Given this list of marker genes Gigyf1, Tlcd4, Qki, Snx27 (NCBI Gene Id 97912), Ifrd1, Ulk2, Zfp607b, Tcf12, Map7d1, C3ar1, Cnr1, Arhgef18, Fbxl2, Marchf6, Exoc5, Atp6v1a, Osbpl8, Sacm1l, B230219D22Rik, Tmem221, Ikzf5 (IKAROS family zinc finger 5), Ntng1, Akap6, Msantd4, Clasp2, Vcan, Zfp644, Mapk1, Pdxp, Prtg, Il2, Nfasc, Nrp1, Pcdh9, Tfap2c, Ywhag, Hcn1, Fam91a1, Cpeb3, Aldh1a1, Mysm1, Bcap29, Spry4, Pdcd10, Abhd18, Adgrb3, Cdc14a, H2az1, Ranbp6, Slain2, Fnip2, Slc6a9, Ero1a, Jazf1, Septin11, Cep15, Rnf145, Tnrc6b, Qser1, Ccdc80, Pym1, Pakap, Astn1, Pdgfra, Zdhhc3, Myrip, Lysmd3, Apbb2, Dcun1d3, Tmem135, Dmwd, B4gat1, Hs2st1, Itpripl2, Reck (NCBI Gene Id 53614), Lmbrd1, Gria4, Zfp597, Kmt2a, Sipa1l2, Dusp3, Ppfia1, Prkce, Ct55, Chic1, Dstyk, Tada1, Arpc5, Hic2 (hypermethylated in cancer 2), Plcxd2, Stxbp5, Rnft1, Arfgef3, Tgfbr1, Tmem237, Urgcp, Ints8, Ralgps1, Mybl1, Jag1, Atxn1, Kif1c, Tm4sf1, H2az2, Zfp850, Entrep2, Zfp606, Cfap97, Atxn7, Rdx, Myt1l, Adck2, Gucy1a1, Pou4f2, Rsad2, Plscr4, Zeb1 (zinc finger E-box binding homeobox 1), Ppfibp1, Bicd2, Ctbp2, 4921524J17Rik, Etnk1, Stag1, Brd3, Rtn4rl1, Iqschfp, Pappa, Gls, Mrpl17, Slc19a2, Nufip2, Ttpal, Gna13, Ntrk2, Epn1, Glcci1, Crebrf, Olfm1, Crlf3, Prkacb, Elavl2, Mtmr6, Kctd8, Lbr, Hook1, Ppp1r15b, Tbc1d1 (TBC1 domain family, member 1), Elk3, E2f3, Phyhipl, Npas3, Adpgk, Simc1, Klf12, Yaf2, Ezh1 (enhancer of zeste 1 polycomb repressive complex 2 subunit), Tmtc1, Ythdf2 (YTH N6-methyladenosine RNA binding protein 2), Dr1, Rarb, Bahd1, Map3k3, Pik3ca, Zcchc24, Ncoa2, Phc3, Nkd1, Schip1, Efcab7, Nckap5, Phlpp1, Cryz, Tcerg1, Pphln1 (NCBI Gene Id 69779), Arl4a, Src, Pgrmc2, Klf6, Stk17b, Dolpp1, Myadm, Kbtbd4, Lrrc8a, 9330159F19Rik, Atrnl1, Unc5c, Aco1, Bend3, St3gal3, Hnrnpf, Siglecf, Zfr, Rab38, Htr5a, Sfpq, Slk, Shisa2, Fkbp5, Mme, Ptprg, Cers6, Tmed9, Dtwd2, Stx2, Mal2, Slc23a2, Zeb2, Slc30a7, Osbpl11, Ccdc177, Ppm1l, Wdfy3, Zyg11b, Ctag2, Thrb, Dnajc13, Sema6a, Epha7, Elmod1, Gata6, Cyth3, Cfap20dc, Klhl28, Rheb, Ppm1e, Kcna4, Dek, Ttr, Fam227a, Tmeff1, Cep43, Cdk13, Tshz3, Ankrd44, Zfp846, Fat3, Ccne2, Angptl2, Slc6a14, Lhx6, Adck1, Cyp26b1, Myh10, Hmg20a, Greb1l, Sorbs2, Mindy3, Trhde, Ctnnd2, Iqsec1, Gpc2, Rb1cc1, Canx, Tgfb2, Ptpn21, Oosp3, Phlpp2, Gon7, Chd2, Ikzf2, Samd8, Ttbk2 (NCBI Gene Id 98929), Nipal3, Dcp2, Sp4, Ash1l, Mbnl1, Ccp110, Cdc25a, Setdb2, Atad2b, Pds5b (NCBI Gene Id 209286), Rnf122, Rhpn2, Stat5b, Osbpl6, Sobp, Slc30a1, Prkcb, Etl4, Tfap2b, Cd247, Abl2, Msantd2, Bivm, Supt6, Gcnt2, Psat1, Carnmt1, Il13ra2, Acvr2a, Map2k4, Ythdf3 (YTH N6-methyladenosine RNA binding protein 3), Cdk8, Zbtb34, Plagl2, Dync1i1, Fmr1, Epha2, Ppt2, Taf12, Ube3a, St3gal5, Atg16l2, Wwtr1, Calcr, Zfp592, Kat6b, Kif3a, Anp32e, Ube2r2, Kif5b, Kcng3, Hephl1, Vsig8, Nr3c1, Grb2, Fam168b, Mbnl3, Camsap2, Hs6st2, Bace1 (beta-site APP cleaving enzyme 1), Rtl5, Tiam1, Sirt1, Lpar1, here is a description of the gene set: species: Mus musculus from publication Chen Y, Wang X (PMID 31504780) Mouse Gene Set: MIR_200A_3P Genes predicted to be targets of miRBase v22 microRNA mmu_miR_200a_3p in miRDB v6.0 with MirTarget v4 prediction scores > 80 (high confidence targets).